Given this list of marker genes ACSM5, MAPRE3, CARNMT1, PSME3IP1, GTF2A1, SPRED3, SLC51A, PDS5A, GJB4, BABAM2, GAMT, SLC24A2, TSPAN9, BEAN1, KLK4, HYDIN, TMEM87B (NCBI Gene Id 84910), CANX, EFCAB13, HUS1, CNNM2, IL22RA2, FSTL1, CSF1, USP34, ZKSCAN7, NCCRP1, CSTPP1 (NCBI Gene Id 79096), PTPN3, HECTD4, DHH, SV2C, FAXDC2, ENTPD5, CIAPIN1, DENND1C, CENPP, GK5, LY6G5C, PAK3, WASF2, PGM2L1, ANKRD63, ZNF614, SFPQ, PPP3R1, BLOC1S3, OLFM2, CASTOR3P, VASH2, SLC17A7, NDST1, GANC, VAMP1, MCMBP, EIF1, TENM2, OAS1, COLQ, SLC4A10, YME1L1, HYKK, NR2C1, BAIAP3, CCNT1, DNAH8, BLTP3A, here is a description of the gene set: Genes predicted to be targets of miRBase v22 microRNA hsa-miR-3126-5p in miRDB v6.0 with MirTarget v4 prediction scores > 80 (high confidence targets). Human Gene Set: MIR3126_5P species: Homo sapiens from publication Chen Y, Wang X (PMID 31504780)